Given this list of marker genes BSG, BBS10, CRB1, TUB, USH1G, CLCN3, RP1, CLN8, RHO, BBS12, ESRRB, NXNL2, NXNL1, SLC2A1, MKKS, DRAM2, TULP1, RP1L1, NPHP4, CDH23, ARAP1, CLRN1, LCA5, BBS2, IQCB1, CNGB1, MAK, BBS4, CDHR1, SPATA7 (spermatogenesis associated 7), USH1C, ABCA4, RDH12, CROCC, ERCC6, ADGRV1, USP45, CIB2, NPHP3, PROM1, PCDH15, BBS1, USH2A, CRB2, ATP1B2, here is a description of the gene set: Any process preventing the degeneration of the photoreceptor, a specialized cell type that is sensitive to light. Human Gene Set: GOBP_PHOTORECEPTOR_CELL_MAINTENANCE studied in species Homo sapiens